Given this list of marker genes UNC119B, VEGFC, RAB22A, SOX9, PMAIP1, MAPK1, SH2D2A, RFC1, BDKRB1 (bradykinin receptor B1), SMTN, SZRD1, MREG, ARL4C, SRRD, SLC35G2, CABIN1, CYP27B1, PHLDA2, APIP, SSNA1, NAV3, ODC1, MRM2, GRB10, PTHLH, VEGFA, GPR153, FOXD1, HPCAL1, ITGA2, TIMM10, SCG5, PLEK2, EGLN1, STC1, CHST11, LYPD3, FST, GFPT1, GIT2, RHOF, TRIB3, POPDC3, here is a description of the gene set: from publication Amit I, Citri A, Shay T, Lu Y, Katz M, Zhang F, Tarcic G, Siwak D, Lahad J, Jacob-Hirsch J, Amariglio N, Vaisman N, Segal E, Rechavi G, Alon U, Mills GB, Domany E, Yarden Y (PMID 17322878) Signaling pathways invoke interplays between forward signaling and feedback to drive robust cellular response. In this study, we address the dynamics of growth factor signaling through profiling of protein phosphorylation and gene expression, demonstrating the presence of a kinetically defined cluster of delayed early genes that function to attenuate the early events of growth factor signaling. Using epidermal growth factor receptor signaling as the major model system and concentrating on regulation of transcription and mRNA stability, we demonstrate that a number of genes within the delayed early gene cluster function as feedback regulators of immediate early genes. Consistent with their role in negative regulation of cell signaling, genes within this cluster are downregulated in diverse tumor types, in correlation with clinical outcome. More generally, our study proposes a mechanistic description of the cellular response to growth factors by defining architectural motifs that underlie the function of signaling networks. species: Homo sapiens Human Gene Set: AMIT_EGF_RESPONSE_480_MCF10A Genes whose expression peaked at 480 min after stimulation of MCF10A cells with EGF.